The following is a description of a gene set: studied in species Homo sapiens Any process that activates or increases the frequency, rate or extent of transcription of nuclear large rRNA mediated by RNA polymerase I. Human Gene Set: GOBP_POSITIVE_REGULATION_OF_TRANSCRIPTION_OF_NUCLEOLAR_LARGE_RRNA_BY_RNA_POLYMERASE_I, and this is the list of marker genes: MTOR, NCL, PWP1, SMARCB1, SMARCA4, NOL11, IPPK, PIH1D1, MARS1, DDX11